Given this list of marker genes MEX3D, KIF5C, STAU2, DHX36, ZFP36, QKI, PUM2, CASC3, ZNF385A, HNRNPAB, ZFP36L1, CAPRIN1, STAU1, A1CF, FUBP3, BICD1, here is a description of the gene set: Human Gene Set: GOBP_INTRACELLULAR_MRNA_LOCALIZATION studied in species Homo sapiens Any process in which mRNA is transported to, or maintained in, a specific location within the cell.